Given this list of marker genes H19, Psat1, Unc5b, Ly6d (NCBI Gene Id 17068), Ddr1, Dab1, Tmem71, Itga6, Phgdh, Mcm6, Afp, Isyna1, Ccdc120, Nupr1, Jun, Spink1, Ifit2, Sidt1, Bmp7, Cxadr, Ccnb1, Myef2, Mep1b, Tspan8, Serpine1, Psrc1, Nid1, D17H6S56E-5, Aebp1, Ube2c, Tpm1, Pck2, Cdkn2b, Igfbp1, Plek2, Gpc3, Pygb, Gm4836, Ocstamp, Fabp4, Mki67, Galnt6, Itih5, Gyg1, Ltb, Col1a1, Cyp17a1, B4galt6, Akr1c18, Mycn, Robo1, Rhoc, Tff3, Ces2c, Tnfrsf12a, Scd2, Slpi, Bex3, Igdcc4, Bex1, Lcn2, Cdh1, Maff, Esm1, Tgfbr2, Pglyrp1, Nucb2, Spred1, Prom2, Prom1, Tubb6, Ehd4, Fabp5, Sparc, Tmem191 (NCBI Gene Id 74063), Calml4, Ifi27l2b, Tlr1, here is a description of the gene set: Cluster PAM3: genes most highly up-regulated in hepatocellular carcinoma (HCC) vs normal liver tissue from mice deficient for TXNIP. from publication Sheth SS, Bodnar JS, Ghazalpour A, Thipphavong CK, Tsutsumi S, Tward AD, Demant P, Kodama T, Aburatani H, Lusis AJ (PMID 16607285) studied in species Mus musculus The molecular pathogenesis and the genetic aberrations that lead to the progression of hepatocellular carcinoma (HCC) are largely unknown. Here, we demonstrate that the thioredoxin interacting protein (Txnip) gene is a candidate tumor suppressor gene in vivo. We previously showed that the recombinant inbred congenic strain HcB-19 has a spontaneous mutation of the Txnip gene, and we now show that the strain has dramatically increased incidence of HCC, and that the HCC cosegregates with the Txnip mutation. Approximately 40% of the Txnip-deficient mice developed hepatic tumors with an increased prevalence in male mice. Visible tumors develop as early as 8 months of age. Histological analysis confirmed the morphology of HCC in the Txnip-deficient mice. Molecular markers of HCC, alpha-fetoprotein and p53, were increased in tumors of Txnip-deficient mice. The upregulation of p53 preceded tumor development; however, bromodeoxyuridine (BrdU) labeling of normal hepatic tissue of Txnip-deficient mice did not reveal increased cell proliferation. Finally, microarray analyses of tumor, non-tumor adjacent, and normal tissue of Txnip-deficient mice highlighted the genetic differences leading to the predisposition and onset of HCC. Our findings suggest that Txnip deficiency is sufficient to initiate HCC and suggest novel mechanisms in hepatocarcinogenesis. Mouse Gene Set: SHETH_LIVER_CANCER_VS_TXNIP_LOSS_PAM3